Given this list of marker genes EPHB4, FLT4, GJC2, ANGPT2, PIEZO1, here is a description of the gene set: Angiosarcoma Human Gene Set: HP_ANGIOSARCOMA studied in species Homo sapiens